Given this list of marker genes LDB1, ASPM (NCBI Gene Id 93990), DNAJC13, EPHB6, SFPQ, MCAM, PHIP, SMC4, PLPPR2, N4BP3, FRYL, ARFGEF1, TFPI, VPS13C, EDEM3, RARRES1, CAV1, USP34, CABP1, TRIM8, KLHL22, SLC4A4, here is a description of the gene set: studied in species Homo sapiens CD24 is a potential oncogene reported to be overexpressed in a large variety of human malignancies. We have shown that CD24 is overexpressed in 90% of colorectal tumors at a fairly early stage in the multistep process of carcinogenesis. Anti-CD24 monoclonal antibodies (mAb) induce a significant growth inhibition in colorectal and pancreatic cancer cell lines that express the protein. This study is designed to investigate further the effects of CD24 down-regulation using mAb or small interfering RNA in vitro and in vivo. Western blot analysis showed that anti-CD24 mAb induced CD24 protein down-regulation through lysosomal degradation. mAb augmented growth inhibition in combination with five classic chemotherapies. Xenograft models in vivo showed that tumor growth was significantly reduced in mAb-treated mice. Similarly, stable growth inhibition of cancer cell lines was achieved by down-regulation of CD24 expression using short hairpin RNA (shRNA). The produced clones proliferated more slowly, reached lower saturation densities, and showed impaired motility. Most importantly, down-regulation of CD24 retarded tumorigenicity of human cancer cell lines in nude mice. Microarray analysis revealed a similar pattern of gene expression alterations when cells were subjected to anti-CD24 mAb or shRNA. Genes in the Ras pathway, mitogen-activated protein kinase, or BCL-2 family and others of oncogenic association were frequently down-regulated. As a putative new oncogene that is overexpressed in gastrointestinal malignancies early in the carcinogenesis process, CD24 is a potential target for early intervention in the prevention and treatment of cancer. Human Gene Set: SAGIV_CD24_TARGETS_UP Genes up-regulated in HT29 cells (colon cancer) after knockdown of CD24 by both RNAi and monoclonal antibodies. from publication Sagiv E, Starr A, Rozovski U, Khosravi R, Altevogt P, Wang T, Arber N (PMID 18413748)